The following is a description of a gene set: studied in species Homo sapiens The chemical reactions and pathways resulting in the breakdown of a pyrimidine nucleotide, a compound consisting of nucleoside (a pyrimidine base linked to a deoxyribose or ribose sugar) esterified with a phosphate group at either the 3' or 5'-hydroxyl group of the sugar. Human Gene Set: GOBP_PYRIMIDINE_NUCLEOTIDE_CATABOLIC_PROCESS, and this is the list of marker genes: NTHL1, DPYD (dihydropyrimidine dehydrogenase), NT5C, NT5M, DCTPP1, TDG, ENTPD4, ENTPD7, UPB1, UPP1, TYMP (NCBI Gene Id 4334), UPP2, UNG, NEIL2, MBD4, OGG1, SMUG1, NEIL1, DPYS, ENTPD5, DUT